The following is a description of a gene set: species: Mus musculus Mouse Gene Set: GOBP_TRANS_SYNAPTIC_SIGNALING_BY_LIPID Cell-cell signaling from post to pre-synapse, across the synaptic cleft, mediated by a lipid., and this is the list of marker genes: Plcb1, Mgll, Faah, Abhd6, Grm5, Nrxn1, Fabp5, Dagla, Cnr1, Cnr2, Pak1, Cnrip1, F2r